Given this list of marker genes SPATA7 (NCBI Gene Id 55812), ALDH3A2, LCA5, KIAA1549, PDE6C (NCBI Gene Id 5146), ELOVL4, RPGR, TOPORS, CYP4V2, PDE6H, SNRNP200, RLBP1, BEST1, TUB, IFT43, PNPLA6, ALMS1, TLCD3B, TRNT1, CNGB3, ATF6, CDHR1, CNGA3, PRPH2, IMPG2, SAMD7, VCAN, RS1, RPE65, ABCA4, IDH3A, LRAT, OFD1, PROM1, GNAT2, MFRP, PRPF6, RDH11, C1QTNF5, ZNF408, CRX, TIMP3, here is a description of the gene set: Atrophy (loss or wasting) of the retinal pigment epithelium observed on fundoscopy or fundus imaging. Retinal pigment epithelial atrophy species: Homo sapiens Human Gene Set: HP_RETINAL_PIGMENT_EPITHELIAL_ATROPHY